Given this list of marker genes RAB22A, CACNA1S, UTP18, DIAPH3, STAT5B, DNAJC15, CXCL10, ASS1, MST1R, KANSL3, OSBPL3, OTUD4 (NCBI Gene Id 95936), TSPOAP1, METTL22, ISG15, SLC39A13, IKZF2 (NCBI Gene Id 51173), DNAAF5, POLR1B, MXD1, SNX25, RIPK1, PRKX, PDCD1LG2, SMC3, RBM47, CPEB4, TUBA1B, CMC2, GSTT1, ZBP1, VEGFC, RAP1GAP, MMP1, ZIC2, HSPA1L, MAPK6, OAT, NLN, EFCAB3, STX11, IL12B (NCBI Gene Id 7907), AARD (NCBI Gene Id 441376), MARCKSL1, ALDH1A2, CNOT9, KARS1, RANBP1, ACBD3, COQ8B, CASP12, CABP4, ANKRD37, SPHK1, P4HA1, FLG, FLNB, TLCD1, CMTR1, TRIB1, MAX, CDKN1A, PDE1B, GLS, EXD1, KCNJ2, TNFAIP3, P2RY13, TMEM236, BAIAP2L1, CD80, CA2, PRDM4, SMG1, HECTD4, CD83, KRT1, ALG9, STXBP1, IL21R, RAB27A, NIPAL1, CTPS1, GLIPR1L2, CD274, CYP27B1, CDKN2B, KLRC3, VRTN, NUP155, TSSK2, CD70, RNF19B, LONP2, PHLPP1, CSNK2A1, PARP4, PDLIM5, LRAT, AMN, RABGGTB, HLA-DRA, ARMCX6, PKD2, FAM89A, MIEN1, DUSP14, CAMSAP2, MYO10, HOXA1, NUDT17, GBP7, JAG1, SULT4A1, CALHM4, SEPTIN3, PSORS1C2 (psoriasis susceptibility 1 candidate 2), ICAM1, IL27RA, CRIP1 (NCBI Gene Id 1396), TANC1, ARFGEF1, RBM27, CHD7, SENP3, FBXO6, CALR, ATP5MC3, PHF24, FABP7, TOP2A, GPR132, RMDN3, MYLK (NCBI Gene Id 50483), BMPR2 (NCBI Gene Id 659), RNF19A, PLAGL1, OSBPL1A, ELP5, DCBLD2, HIF1A (hypoxia inducible factor 1 subunit alpha), MARCHF3, BBX (NCBI Gene Id 56987), LRRC4, MPP3, URB2, EAF2, LMTK2, INPP4A, SEMA4C, HAT1, IKZF4, CD69, PPARGC1B, SH3PXD2B, SLC3A2, MFSD2B, NAPEPLD, ALDH18A1, TENT5C (terminal nucleotidyltransferase 5C), CD38, LRRC41, JRK (NCBI Gene Id 8629), TTC29, ZFR, TECRL, ZFHX4, UBAP2, CLEC4E, DUSP5, ATP6V1B2, PIK3AP1, CASP4, MAP3K14, CXCL11, USP39, MYO9A, C3orf62, TMEM39A, RHOC, SCN2A, CACNB1, SLC41A1, APOBEC3B, MAGED1, KTN1, FAM241A (family with sequence similarity 241 member A), CC2D1B, GYG1, SNN, RELB, RASA2, CUTA, SF1, SSH3, MFSD1, NLRC5, MKI67, TXN, ARAP3, here is a description of the gene set: Bcl6 germline deletion causes a prominent inflammatory disease, owing to over-expression of Th2 cytokines, and affects the properties of B cells prior to immunization. Therefore we established the B cell-specific Bcl6 deletion mice and analyze the gene expression of naive B cells under physiological conditions. species: Homo sapiens from publication Kaji T, Ishige A, Hikida M, Taka J, Hijikata A, Kubo M, Nagashima T, Takahashi Y, Kurosaki T, Okada M, Ohara O, Rajewsky K, Takemori T (PMID 23027924) Genes down-regulated in marginal zone B lymphocytes: wildtype versus heterozygotic knockout of BCL6. Human Gene Set: GSE28737_WT_VS_BCL6_HET_MARGINAL_ZONE_BCELL_DN